The following is a description of a gene set: Human Gene Set: HP_MUSCLE_FIBER_SPLITTING Muscle fiber splitting studied in species Homo sapiens Fiber splitting or branching is a common finding in human and rat skeletal muscle pathology. Fiber splitting refers to longitudinal halving of the complete fiber, while branching originates from a regenerating end of a necrotic fiber as invaginations of the sarcolemma. In fiber branching, one end of the fiber remains intact as a single entity, while the other end has several branches., and this is the list of marker genes: ADSS1, TRPV4, NEFH, DYSF, FLNC, CRYAB, NEB, DNAJB6, TPM2, COL6A2, SGCG, ACTA1, TTN, CHRNB1, PLEC, MAP3K20, ANO5, LDB3, CAPN3, MYOT, PLIN4, ALDOA, TNXB